The following is a description of a gene set: species: Homo sapiens Human Gene Set: GOBP_REGULATION_OF_ACTIN_FILAMENT_BASED_MOVEMENT Any process that modulates the frequency, rate or extent of actin filament-based movement., and this is the list of marker genes: PDE4D, PKP2, STRIT1, ATP2A2 (ATPase sarcoplasmic/endoplasmic reticulum Ca2+ transporting 2), CAV3, MYBPC3, ADCY10, DSG2 (desmoglein 2), ATP1A2, ANK2, JUP, GJA5, TRPM4, ACTA2, ZEB2, DLG1 (discs large MAGUK scaffold protein 1), CAV1, RANGRF, STC1, FGF13, SCN5A, PDPN, DSC2, TNNC1, GATA4, ATP2A1, DSP, CAMK2D, BIN1, MYLK2, HCN4, AKAP9, ADORA1, CACNA1C, RYR2, SRI, PLN, KCNJ2, MYH7B, SUMO1, CTNNA3, PDE4B, MIR448 (NCBI Gene Id 554212)